Given this list of marker genes ALDH5A1, APP, PLAU, USP53, MPO, NOS3, here is a description of the gene set: studied in species Homo sapiens Any deviation from the normal concentration of gamma-aminobutyric acid (GABA) in the blood circulation. Human Gene Set: HP_ABNORMAL_CIRCULATING_GABA_CONCENTRATION Abnormal circulating GABA concentration